Given this list of marker genes RAB21, RDX, MSN, SNX3, MAPK3, DENND10, SRC, NF2, DNAJC13, MAP2K2, MAPK1, VPS11 (NCBI Gene Id 55976), EZR, PTPN23, MTMR2, MAP2K1, SNX12, CHMP3, DAB2, here is a description of the gene set: species: Homo sapiens Any process that modulates the frequency, rate or extent of early endosome to late endosome transport. Human Gene Set: GOBP_REGULATION_OF_EARLY_ENDOSOME_TO_LATE_ENDOSOME_TRANSPORT